The following is a description of a gene set: The series of events required for an organism to receive a sensory stimulus, convert it to a molecular signal, and recognize and characterize the signal. This is a neurological process. Mouse Gene Set: GOBP_SENSORY_PERCEPTION studied in species Mus musculus, and this is the list of marker genes: Or8g55, Or12k8, Or2b6, Or5an11, Or7g16, Htr7, Or2a14, Mir706 (microRNA 706), Or4c118, Or8g32, Vmn1r41, Or2ak6, Tbl1x, Espn, Hoxa1, Lpo, Or5ak4, Or8b53, Or5bh3, Or13a17, Or52a5b, Or5ak22, Or14a260, Myo7a, Or5bb10, Grm6, Or52h9, Or52z12, Or14c44, Or7g12, Mir199b, Or2t26, Or13p3, Or4c108, Or5ac19, Or2v2, Or6c213, Tomt, Kcnq2, Or8b52, Chrna10, Or12e14, Bsnd, Col1a1, Usp53, Or4p19, Tas2r137, Or1e35, Or8c17, Nherf2, Nob1, Or1p1, Or4z4, Nipbl, Or10ab4, Or5al6, Taar7f, Or6d15, Or8b36, Oprm1, Nmur2, Or9g4, Tmem100, Or8g19, Or52n5, Or52m2, Rdh12, Or4c124, Or7a35, Mir182, Or1d2, Npy1r, Mir34a, Olfr908, Or4x11, Or1aa2, Or7e176, Cngb3, Tas2r107, Or9k2b, Crygc, Or14j9, Or2h15 (NCBI Gene Id 435547), Or10ag60, Cdh23, Or52r1, Or6k2, Myo5a, Or5ac25, Or5an6, Strc, Rho, Or12e10, Or51a6, Wdr1, Vmn1r44, Or2y17, Or51ac3, Ush2a (usherin), Or1j21, Crygn, Or8c18, Or2t47, Dnajc19, Or52n2c, Or10ak13, Mir130b, Cacna1d, Or4a39, Or2q1, Or8k16, Tas2r117, Or4g17, Or2ab1, Or6c207, Or5ac21, Or7g19, Or6c3, Mir345, Or5p56, Or4c35, Mme (membrane metallo endopeptidase), Or13p5, Or14a257, Or5w11, Mir193b, Mip, Or8k27, Pcdh15, Or2a52, Or4c12, Or8b3b, Or5w1b, Or2t44, Or4a75, Best2, Cldn19, Or10g3, Or14a258, Or5p6, Or6c206, Or12e9, Or5an1b, Or5t7, Grm3, Or4x6, Or1q1, Col6a1, Or2y1f, Rdh8, Or52b2, Kcnd2, Or14a259, Kcnk9, Or6b6, Otog, Or5p73, Or7g30, Or4k15, Or4g16, Chrnb2, Or8g4, Or4c10b, Or10ag2, Or56b34, P2rx4, Or13c7, Or7g17 (NCBI Gene Id 259070), Or2d3c, Or52ac1, Or7g20, Impg1, Or52n20, Scn9a (NCBI Gene Id 671835), Or2y1c, Or6c76b, Or5p5c-ps1, Or8g27, Spata7, Or1x2, Or51a42, Or52e4, Or52j3, Or5p1, Ano1, Or5g25, Rp1l1, Cnga1, Gip, Or2a51, Scrn3, Mapk3, Cryga, Or5p58, Or9r7, Pou3f4, Or13a21, Or1e1f, Adcy3, Slc4a10, Or13a20 (NCBI Gene Id 258962), Tafa4, Or9i2, Or51f23, Or8b42, Smr2l, Mir199a-1, Col11a1, Tmc4, Obp1b, Or8k3b, Or8d1b (NCBI Gene Id 258433), Or5h25, Or2a20, Or4x15, Or5m10b, Or8g53, Bbs2, Or2ag15, Cplx4, Or4k49, Or52p1, Or2ag20, Or6c70, Or1ad8, Or6z5, Or9i1, Or2w3b, Comt, Tas2r135, Or10d4, Fabp5, Or8k23, Tectb, Lxn, Ccdc154, Or5w14, Epas1, Or8c11, Vmn1r43, Aloxe3, Or4d1, Serpinb6c, Or5k14, Or5m9b, Trpa1, Glra1, Or56a4, Or4c107, Or11n2, Or2n1e, Or9q2, Or13g1, Or5b21, Or11g27, Pomk, Or6k6, Or5b104, Or5b107, Slc52a3, Or5h22, Or51a25, Or6c6, Pomgnt1, Or11g25, Ffar4, Or9e1, Or5m3b, Or1j12, Or5ae1, Rrh, Or13c25, Or10d4b, Fzd4, Grm8, Mir29b-2, Or8b43, Or12j5, Or9a2, Or10a5, Or5b113, Or10ag59, Omp, Oprk1, Or5d43, Pdcl, Or1n1b, Or4f15, Scn8a, Mir28a, Or6c65, Or5p80, Lypd6, Slc6a3, Ifng, Or5w1, Hpn, Trpm8, Barhl1, Or12d12, Cnga3, Mgll, Or10a49, Rgs21, Or4f61, Vmn1r54, Or8b12i, Gucy2f, Or4k5, Tas2r109, Or4a79, Or10w1, Or5b94, Or4x13, Or4a71, Cdkn1b, Or6c5, Tac1, Or14j1, Or10ak12, Or51b17, Nherf1, Or56b6, Or4k52, Or1o11, Or4k39, Or5i1 (NCBI Gene Id 258640), Or8h7, Nmu, Or8b9 (olfactory receptor family 8 subfamily B member 9), Or52e3, Or2l13b, Mir361, Or10al6, Mirlet7d, Or4c125, Or2g1, Or8u10 (olfactory receptor family 8 subfamily U member 10), Or14a256, Or8k40, Or4p18, Or14j2, Or2ag1, Or10j3, Or10v1, Slc24a1, Elfn1, Or10ak16, Mir542, Tbx1, Or8c15, Or51ab3, Or5h18, Crybg3, Or2ag2b, Or7a38, Tas1r1, Cacna1e, Mir322, Grin2d, Or3a4, Or52u1, Aqp4, Or2m12, Or9g3, Gnb1, Casp3, Or8k37, Triobp, Or5k1, Or2g7, Mfrp, Tshz3, Tas2r130, Pou4f3, Cryba4, Or7a39, Mir181d, Gjb2, Mir181a-1, Or6d12, Ceacam16, Or2y1g, Or4f56, Col11a2, Serpinb6d, Kcnk2, Vmn1r42, Or7a40, Mir501, Mir744, Or4b1b, Or6b3, Or8c9, Tas2r103, Or4b1d, Or2ag16, Opn1mw, Or12e13, Or2w4 (NCBI Gene Id 404503), Vmn1r15, Mirlet7g, Or12k7, Or5m12, Nlgn2, Slc12a2, Or5g26, Slc4a7, Or1e34, Or4f14b, Or4c15, Or10h1b, Gjb6, Or4c1, Or4n4b, Or4k15b, Or5v1, Or51ai2 (olfactory receptor family 51 subfamily AI member 2), Map1a, Or5c1, Hexb (hexosaminidase B), Opn1sw, Lrig1, Or8k38, Mir298, Or1e17, Vmn1r50, Rs1, Or51r1, Mir491, Or1j19, Or5w18, Or5m11b, Or10d1b, Or2t6, Or52b1, Lhfpl5, Or51aa2, Or2h1b, Or5an9, Chd7, Mir146b, Or51g2, Or56b35, Cabp1, Or4k44 (olfactory receptor family 4 subfamily K member 44), Or14j4, Gm7582, Or8d2, Or52e8, Or6b1, Or8b47, Bbs10, Or7g35, Crybb3, Serpine2, Rdh11, Ankfn1, Mir467a-4, Or5p50, Or2ag1b, Tlr4, Or8k25, Or10u4, Or5p52, Tprn, Mir151, Cdh1, Or1e26, Cxcl12, Or2a5, Or8b37, Or6a2, Or51a5, Irx5, Or5v1b, Or2ag13, Serpinb6b, Kcnq4, Or10ag58, Or5p63, Gjb4, Or4c10, Myo1a (NCBI Gene Id 632872), Kcnj10, Mir92-2, Or52e5, Or2w25, Or52b4, Cryba1, Or10g6, Or10am5, Mir181c, Or2k2, Gm7609, Or5an1c (NCBI Gene Id 258683), Or6c69, Rnf170, Tas1r2, Or6b9, Or5al5, Or12j2, Mpv17, Or51m1, Grk1, Kcnip3, Or5p81, Coch, Or52e19b, Or52n2b, Mir338, Tas2r131, Mir296, Or14c39, Or10ac1, Or8k24, Or5w8, Pgap1, Or4k48, Or1j1, Or4f52, Or52n1, Or5p57, Or8g26, Ankrd24, Or52ab2, Or51i2, Or4n4, Or14j3, Or52e18, Or5d20-ps1, Gnal, Or5ap2, Or9m2, Or52r1b, Atp8a2, Or13a19, Mir125b-2, Opn4, Or5al7, Or52s1b, Or2d3b, Cnnm4, Or5p55, Or3a1, Or10ad1c, Tulp1, Fyn, Gja3, Or5d14, Or51f23b, Taar3, Or13a25, Or13e8, Or4f7 (NCBI Gene Id 404369), Rpgr, Or5b116, Cnga2, Or52x1, Or5an10, Mirlet7a-1, Or5b97, Ucn (NCBI Gene Id 22226), Or5p53, Myo3a (myosin IIIA), Ush1g, Pde6a, Or5ar1, Large1, Or5k1b, Or5h17, Or5af2, Or5g29, Or5d44, Or4c52, Or4c115, Or7g25, Or5aq7, Rtp4, Nr2e1, Or1e25, Or6x1, Or11i1, Or5b111, Or14j5, Tas2r126, Or4k42, Cfap69, Or5p61, Or6k14, Or13c3 (NCBI Gene Id 258821), Tas2r125, Bpifb9a, Atp8b1, Or4k77, Diaph3, Or55b3, Or2n1b, Or7e177, Mir23a, Or10a4, Or8k53 (olfactory receptor family 8 subfamily K member 53), Mir674, Or4c105, Guca1a, Or5p79, Or10d1c, Or4k6, Or4a69, Or51a10, Or8g37, Crybb2 (NCBI Gene Id 12961), Or10ag54, Opn5, Or8b40, Or5d47, Or8i2, Mir467a-1, Or11h7, Sema5b, Rgr, Or7g18, Or2m13, Or5l14, Or5w12, Stx4a, Or8w1, Or2aj5, Or4k2, Mir329, Lrat, Or11g1, Atp6v0a4, Myo7b, Or5d45, Or51l14, Or4f14d, Or8j3c, Zfhx2, Mir20b, Or6ae1, Or4b1c, Or1e30, Mir34c, Or4c117, Ush1c, Mir195a, Or9g4b, Rorb, Or5ak24, Or8g50, Lhfpl4, Or4c123, Mir96, Itga2, Cplx3, Asic1, Or51l4, Or8b50, Elmod3, Or6c76, Or4c110, Or6z3, Or2ak4, Crym, Or12d16-ps1, Nr2f6, Or6c215, Or5e1, Tas2r119, Serpinb6a, Vmn2r26, Nav2, Or55b4, Or1e29, Or52n4b, Mir24-1, Or6k4, Slitrk6, Or1j13, Or14j10, Or6k8-ps1, Pdc, Or1e16, Or5aq1b, Cpeb3, Grik2, Or8d23, Or51k1, Atp2b2, Cryaa, Pkd2l1, Grin2a, Mir429, Or2o1, Vmn1r10, Or4f62, Or5ac17, Or5k3, Or8j3b, Or52d3, Or6b13, Or8g35, Cryge, Or2h1, Tbx18, Or8b39, Or11h4b, Pawr, Or2w1b, Disc1 (NCBI Gene Id 640053), Or5b109, Psap, Fgfr1, Azgp1, Or7d11, Ppef2, Mir24-2, Or2t48, Or9r3, Pou4f2, Alms1, Or10al5, Or8k41, Or5a3, Or8d2b, Fzd2, Or6c63-ps1, Or6c219, Lrp2, Or2t35, Or5b12, Or7c19, Or8g18, Pirt, Rgs9bp (regulator of G-protein signalling 9 binding protein), Cacna2d4, Minar2, Or4q3, Hoxd1, Or10d5, P2rx7, Or2y11, Gja10, Tmie, Tmem120a, Sobp, Or7a37, Or10u3, Or2a12, Or8b38, Bfsp2, Ptprq, Or10al4, Tas2r105, Or51h5, Or2y1b, Cacnb4, Or9s13, Or7g26 (olfactory receptor family 7 subfamily G member 26), Tas2r118, Tas2r134, Or10al2, Crygb, Or12d17, Or8h6, Or8c20, Tas2r122, Or4e2, Th, Or8k30, Tas2r104, Or4c106, Mir148b, Clrn1, Or8b55, Or5d38, Spx, Rgs9, Scnn1b, Mir99b, Or7c70, Cln5, Or11g24, Or10d5j, Or5k17, Mir326, Scarb2, Olfm2, Or6c2b, Mir16-1, Or10v5 (NCBI Gene Id 258938), Crygs, Opa1, Or5ak20 (NCBI Gene Id 258166), Or8u3-ps (olfactory receptor family 8 subfamily U member 3), Or4c12b, Gpr171, Mir467a-3, Or4c116, Or5w15, Or52a24, Npr2, Epyc, Gpr179, Or8b54, Slc17a8 (solute carrier family 17 (sodium-dependent inorganic phosphate cotransporter), member 8), Or5w16, Shank1, Or14j6, Or12e1, Or4a77, Or6c6c, Or1ab2, Or4e5, B3gnt2, Or4k1, Mir146, Or8k32, Or52h2, Ndn, Atp6v1b1, Or51k2, Or5w20, Mir532, Slc45a2, Ric8b, Or8k28, Or5ac20, Tas2r143, Or10ag52, Mir467a-9, Pip, Or6z6, Or51s1, Or5p51, Or5b120, Crygf, Or12d13 (NCBI Gene Id 258830), Or8b4, Or2w1 (olfactory receptor family 2 subfamily W member 1, NCBI Gene Id 258253), Or6c211, Or5k15, Snai2, Or10g1b, Or5al1, Tas2r114, Kcnq3, Marveld2, Vmn1r49, Or1n1, Or51v14, Or10h28, Or2w6, Or8b1c, Cngb1, Or7g32, Or4d2b, Or5d3, Or2y15, Or51q1, Or2n1d, Or1i2, Or51a8, Or6s1, Or2b28, Or51ah3, Or1e23, Or13a27, Or10d3, Or3a1c, Or10d1, Tas2r121, Or8g28, Ntsr1, Or5m5, Vmn1r45, Rtp1 (receptor transporter protein 1), Asic3, Scnn1g, Or8g20, Rest, Or6c88, Or8c8, Tmem150c, Or5p78, Or5p69, Or10j2, Tspear, Ccr2, Mir106b, Or5an1, Glrb, Or52s6, Or51b6b, Or2a7, Or5b105, Or5b117, Eya4, Gfy, Or8g23, Mc1r, Tjp1 (tight junction protein 1), Or4c111, Or52ae7, Or52z13, Spns2, Or11h6, Or5b124, Or10z1, Or5g27, Or10h5, Or8g33, Or6z7, Or9k7, Or1e19, Get1, Or4p22, Or6c2, Or1j10, Hoxb8, Or12d14-ps1 (NCBI Gene Id 257948), Ppt1, Gjc3, Or5b123, Or6c33, Grm7, Rom1, Or2aa1, Or13a22, Or2h2c, Or51f5, Or2y12 (NCBI Gene Id 257971), Or10k2, Grin2b, Or14c41, Mir1195, Or2aj4, Sod2, Or4a68, Or13c7d, Igf1, Gbx1, Or8c13, Scn1a, Or52w1, Cdkn2d, Tas2r136, Cd36, Tmc7, Aqp1, Or2r2, Rpgrip1, Or5p68, Htr2a, Or14j7, Or10aa3, Or7e175, Or56a5, Or6c210, Or6c6b, Olfr363-ps, Mir762, Or9s18, Or6f1, Or6c66b, Mecp2, Cacnb2, Abca4, Or8g21, Or5b24, Rlbp1, Asic2 (acid-sensing ion channel 2), Or5g23, Myc, Or13ae2, Or6n2, Drd2, Mir467a-8, Or12e8, Or11q2, Or6d13, Lrit3, Or10x4, Reep6, Or5d41, Dll4, Best1, Or51v8, Or5p62, Mir23b, Pde6h, Gpx1, Thrb, Or5b96, Or12j4, Or8b3, Btbd9, Or5d46, Rab3a, Mir25, Lrit1, Or6c208, Or4k40, Mir455 (NCBI Gene Id 735262), Scnn1a, Or2j6, Or13a26, Or4c122, Or1n2, Srrm4, Or9a7 (NCBI Gene Id 258380), Scn10a, Clrn2, Crb1, Or52ab7, Or7g33, Grin1, Or8j3, Or6n1, Or5h26, Blvra, Or4b1, Or52s1, Calhm1, Retreg1, Slc24a4, Or5m10, Or2ah1, Or12k5, Or5ak23, Or10g1, Or10g9b, Or1o4, Tmtc4, Serpinb6e, Phf24, Or11g26, Or5b95, Or4k36, Mir141, Rtp3, Or7h8, Or10g3b, Or10al3, Arrb2, Or2y1e, Calca, Or1o1, Or2y10, Kcnma1, Or2y1d, Or11a4, Pkhd1l1, Or14j8, Or6b2, Or7e169, Or11m3, Rbp4, Or8b46, Or1af1 (olfactory receptor family 1 subfamily AF member 1), Mir467a-10, Vmn1r52, Or51i1, Mir652, Or5aq1, Or6z1, Vmn1r48, Unc119, Or5d16, Tas2r123, Or2t46, Or2t45, Or10ag57, Tas2r113, Ephb1, Or5t15, Slc26a5, Or6c212, Or4k51, Or7g22, Or5b112 (olfactory receptor family 5 subfamily B member 112), Tmc2, Smr3a, Or5bw2 (olfactory receptor family 5 subfamily BW member 2), Adgrv1, Loxhd1, Kit (NCBI Gene Id 16590), Or2a25, Cemip, Or4d2, Kcna1, Or8b12b, Or6c205, Gm15433, Mir324, Mir711, Cfh, Or51ag1, Mbp, Or10ab5, Vmn1r25, Or10q12, Or5p70, Or13d1, Cntn5, Mapk1, Or51a7, Or5d35, Or8g22, Prx (NCBI Gene Id 233019), Or2y8, Mir30d, Or51a24, Obp1a, Or4c29, Or13a24, Or2t1, Or1e1, Or4d5, Or8k20, Or2ag18, Or51b6, Or4a81, Or8b12c, Mir20a, Or6c5c, Homer2, Or1e21, Crygd, Or51e1, Otogl, Or8b12, Or9g20, Or51f2 (NCBI Gene Id 259095), Or10a3, Or5b98, Or8c10, Or52e7 (NCBI Gene Id 259099), Or10ak8, Cdk5, Adora1, Or14c43, Or5p59 (olfactory receptor family 5 subfamily P member 59), Or52r1c, Mcoln3, Mir205, Or5p76, Or6b2b, Or2h2, Or1j11, Sptbn4, Or6f2, Or2t49, Or51t4, Kcnk4, Reep2, Pax6, Or52e15, Or5k16, Or2ag2, Or4p20, Or6p1, Tfap2a, Slc1a3, Or2aj6, Mir30b, Kcna2, Sox2, Or51e2, Mir203, Or1b1, Or4f54 (olfactory receptor family 4 subfamily F member 54), Or8d1, Or8a1, Vmn1r46, Or7e170, Or8s2, Or4c100, Or4d6, Tac4, Or4c15b, Or5m9, Or2j3, Or10al7, Dcdc2a, Or10b1, Pde4a (phosphodiesterase 4A, cAMP specific), Or56b1 (NCBI Gene Id 258309), Or6c75, Or8u9, Mir467a-5, Rdh10, Or1ak2, Or4c3d, Or52a5, Or5p4, Or52m1, Or52a33, Or10c1, Diaph1, Tas2r129, Or5b122, Or5o1, Or4c113, Dlg2 (discs large MAGUK scaffold protein 2), Ripor2, Or5ac24, Or2ad1, Vmn1r47, Gng13, Or7e173, Adra2a, Or6d14, Or52h7, Or8g24, Mir17, Or10q1, Or13a18, Mir409 (microRNA 409), Or1o3, Or1a1, Tecta, Or2ak7, Or8g2, Vmn2r1, Grxcr2, Or56b1b, Or2y6, Or5w10, Or52s19, Or1r1, Or11h4, Or10n1, Atf6, Or7e168, Tas2r106, Or14c45, Or9s27, Cdc14a, Lamb2, Or4c3, Or13c7b, Pde6d, Vmn1r239-ps, Or8b41, Pcare, Or10j27, Or5t16, Gnat1, Syt10, Impg2, Or52z1, Pou4f1, Or1j4, Otoa, Tas2r120, Or2b7, Or2r11, Or2z9, Sox14, Or7e174, Vmn1r40, Or8b51, Ptges, Trpm1, Oprl1, Or8a1b, Or4a72, Mir383 (NCBI Gene Id 723860), Or6c200-ps1, Gjd2, Or10ak14, Or9i1b, Lhfpl3, Mir206, Or4f59, Or10q3, Or52d13, Cacna1f, Or4k37, Or2n1, V1ra8, Ccl2, Chrna4, Mir29b-1, Or4c102, Or2a57, Cln6, Or3a1b, Or10ak7, Or8d6, Or6c69b, Or7g34, Tas1r3, Or12d2, Nrg1, Piezo2, Or1j15 (olfactory receptor family 1 subfamily J member 15), Or4c11b, Or1f12, Or1j14 (NCBI Gene Id 258950, olfactory receptor family 1 subfamily J member 14), Pde6b, Or1ad6, Or4k15c, Crx, Fxn, Or3a1d, Or9m1, Or1j18, Trpv1, Mir331, Or5b99, Or2c1, Vsx2, Or10x1 (NCBI Gene Id 258238, olfactory receptor family 10 subfamily X member 1), Mir487b, Jag2, Tas2r144, Or2f1b, Or5j1, Or5d39 (olfactory receptor family 5 subfamily D member 39), Or4c31, Or1m1, Or51af1, Ntrk1, Or4a74, Or4c101, Tas2r110, Iapp, Or4c120, Or5h23, Or5ac16, Or10p1, Mir451a, Alg10b, Or9g10, Or5t17 (NCBI Gene Id 258262), Or8h9, Or10d4c, Ulk4, Or4b13, Sema5a, Or6c1b, Or2at1, Vmn1r30, Pjvk, Or2l13, Or52b3, Il18, Rtp2, Ttc8, Or4a47, Pdyn, Eps8l2, Mir93, Or6c69c, Or4n5, Or2ag17, Or10ag56, Or5h19, Or8b101, Or56b2, Gnat2, Or6c66, Fbxo11, Espnl, Or4f17-ps1, Or8b49, Or4f53, Or5p64, Fto, Or55b10, Taar5, Or52z14, Tas2r139, Pnoc, Mir100, Or4l1, Mir351, Or52e2, Or10ag53, Myo15a, Mir200a, Tmc1 (NCBI Gene Id 74462), Or4a66, Or2ak5, Or8k33, Or2i1, Or4c11c, Or8g54, Or8d4, Or7g31, Or4f14, Bbs1, Mrgpra1, Lrig2, Or10a3n, Or4a78, Or52ae9, Or10a3m, Rd3, Or1l8, Or10g9, Or7g28, Or9k2, Or4k41, Or5m3, Or4k35, Or5d18, Or1j20, Or10ah1-ps1, Mir467a-2, Or5h24, Pkd1l3, Or2b2b, Or6c3b, Or52ad1, Enpp1, Or10h1, Rpl38, Mir221 (NCBI Gene Id 723827), Or5m13b, Vmn1r11, Gabrr2, Or5g9, Pde6c, Or11g7, Or2p2, Mir222, Or1j16, Or8s8, Or5as1, Or3a10, Plcb2, Chrna5, Prdm12, Or10j3b, Or4g7, Vmn1r14, Ccl3, Or6c209, Or5p5, Mir22, Slc38a8, Or9i14, Or14c40, Or5ac15, Or4b12, Mir107, Pigr, Tmem63b (NCBI Gene Id 224807), Or5a1, Or52n4 (NCBI Gene Id 259051), Or9g8, Or8b57, Or2ag12, Or2d36 (NCBI Gene Id 258597), Mir671, Or1e32, Arr3, Or56a3b, Tub, Tas2r116, Or6c1, Or5t5, Or4l15, Or4c127, Or9s23, Or13a1, Or8c16, Bace1, Or51h1, Or51aa5, Sod1, Atpsckmt, Or51g1, Or52h1, Or1f19, Or5p67, Whrn, Or5w19, Or12d15, Wfs1, Or4p23 (NCBI Gene Id 404330), Tmem87a, Or5ac22, Or11g2, Or1o2, Gsdme, Or5p72, Or2t43, Abcb1a, Or10s1, Lef1, Wdr47, Or9g19, Or5h27, Or1j17, Grm1, Mir342, Or8s5, Or10ak9, Or51f1e, Or5m13, Or8s10, Or7g27, Smr2, Chrna7, Or6c74, Or5b119, Or4a70, Or2y13, Mir301, Or13c7c, Tnf, Grxcr1, F2r, Or5b106, Or4e1, Or2y16, Or2y14, Or4d11, Or8k1, Or52i2, Ugt2a1, Myo6 (myosin VI), Penk, P2rx2, Or5b12b, Or52e8b, Ubr3, Or2d3, Or4f57, Axin1, Or13p8 (olfactory receptor family 13 subfamily P member 8), Ccdc66, Or52ab4, Dnajc19-ps, Or4m1, Or8b56, Mir140 (NCBI Gene Id 387158), Ddit3, Tas2r115, Nxnl2, Or10g7, Ror1, Or2a54, Or2d2b, Rp1, Or4d10b, Crybb1, Or4a2, Or2b4, Mir31, Or9a4, Or4c109, Or9i16, Or5b3, Or8k3, Or8h10, Mmp24, Or6y1, Rcvrn, Or10p22, Rubie, Or11j4, Or2t29, Chrna9, Or5t9, Or2g25, Or1s2, Or2bd2, Or2b2, Or10j5, Or51b4, Mir199a-2 (NCBI Gene Id 723821), Mir181a-2, Or4f4b, Or8b1d, Mir16-2, Or4c11, Or2av9, Or1j8, Or2w2, Or8k39, Or2l5, Or4a67, Or10a2, Or6c214, Or5ae2, Or8k18, Or5t18, Lamc3 (NCBI Gene Id 99350), Or2a56, Or2y1, Olfr1060-ps1, Mir130a, Or10ad1b, Or10aa1, Or1a1b, Nmb, Vmn1r13, Mir29a, Or8g36, Or8b1b, Or1l4, Or8b48 (olfactory receptor family 8 subfamily B member 48), Rpe65, Tas2r140, Or10a48, Tas2r102, Tas2r124, Mir676, Mkks, Or6aa1, Or5af1, Or8s16, Or2n1c, Kcnq1, Hexa, Or4f58, Calhm3, Or5ac23 (NCBI Gene Id 257881), Mir124a-1hg, Or51a43 (olfactory receptor family 51 subfamily A member 43), Or2ag19, Myo3b, Or4d10, Mir92-1, Mir124-2hg, Mir148a, Or13f5, Mir152, Mir200c, Or13j1, Or4d10c, Or5p60, Or13a28, Or4c103, Or11l3, Or5be3, Or8k17, Or4f6, Or6c203, Zic2, Or4c126, Or4c104 (olfactory receptor family 4 subfamily C member 104), Or51q1c, Rdh5, B2m (beta-2 microglobulin), Cln8, Or7e166, Mir149, Or51d1, Or52l1, Acp3, Mir467a-7, Or8k22, Or51f1d, Cabp2, Or2d4, Or13p10, Or6c68, Fam107b, Or52n2, Or8u8, Or52p2, Or4c121, Or4a76, Otos, Or4c112, Gucy2e, Or4p7, Or4s2b, Or2b11, Or7a42, Or51f1, Vsx1, Or8k35, Or6c38, Or8g34, Or10ad1, Cabp4, Or2r3, Or11h23, Cxcr4, Lctl, Or5d40, Or8g30, Or5b101, Or8b8, Or2y3, Or9s15, Mir27b, Or8h8, Ndufs4, Taar4, Opa3, Or5aq6, Pde1c, Or7e178 (olfactory receptor family 7 subfamily E member 178), Or5d37, Or5j3, Ano9, Or10q1b (olfactory receptor family 10 subfamily Q member 1B), Or7g29, Or5au1, Or4a27, Or2w3, Or2at4, Otof, Or10j7, Myh14, Gnas, Mir434, Or4a15, Mir467a-6, Or14c46, Dmxl2, Or2d2, Or5b108, Or5b121, Or2z2, Or1ad1, Or7a36, Cacnb3, Pdzd7, Or7d9, Wnt10b, Cep250, Or9s14, Or6c202, Or52d1, Mir770, Or10v9, Dram2, Itpr3, Or2f2, Or12j3, Mir125b-1, Vmn1r53, P2rx3, Or5d36, Drgx, Scn11a, Ccdc50, Or8g52, Ngf, Or6c217, Cryba2, Or5b102, Or5ak25, Or8b1, Or10a3b, Tas2r138, Or13n4, Or5m8, Or6c8b, Or2z8, Grap, Guca1b, Or1e1c (olfactory receptor family 1 subfamily E member 1C), Or52a20, Nyx, Or5w17, Clrn3 (NCBI Gene Id 212070), Or4p8, Or2v1, Or6c201, Or4c114, Or8g51, Or52k2, Or4a73, Tmprss3, Ccn3, Or5b118, Or6e1, Or4f60, Or4k45, Mir183, Or6c35, Or8b35, Col2a1, Ppip5k2, Or6c216, Mir200b, Or5w22, Car6, Ppef1, Or4f47, Mir497, Or5p54, Or56a3, Or4k38 (NCBI Gene Id 259136), Six1, Or8g17, Or7g21, Or4k47, Or7a41, Or7e165, Prph2, Or9q1, Or13l2, Pde6g, Or6c8, Or52n3, Clic5, Nipsnap1, Or5l13, Spry2, Or10ak11, Or51a39, Cnga4, Or5w13 (NCBI Gene Id 258653), Or8g2b, Or10p21, Or2f1, Or5p66, Or56b2j, Gnat3, Or9m1b, Vmn1r51 (NCBI Gene Id 22296), Or1e33, Or1e22, Or8b44, D130043K22Rik, Tas2r108, Or12e7, Gucy2d, Bbs4, Vmn1r29, Or7r1, Or7d10, Gjc1, Or4c58, Or13p4, Gprc5c